The following is a description of a gene set: species: Homo sapiens Human Gene Set: KEGG_MEDICUS_VARIANT_MUTATION_ACTIVATED_GNAS_TO_CRHR_PKA_ACTH_SIGNALING_PATHWAY Mutation-activated GNAS to CRHR-PKA-ACTH signaling pathway. Pathway ID: N00326. Pathway type: Variant. Pathway class: nt06360 Cushing syndrome. Pathway Definition from KEGG: GNAS* -> ADCY -> cAMP -> PKA -> CREB -> ACTH, and this is the list of marker genes: ADCY5, CREB3L4, ADCY2, CREB3, CREB5, ADCY3, GNAS, PRKACG, ADCY6 (adenylate cyclase 6), POMC, PRKACA, ADCY9, ADCY4, ADCY8, ATF2, ADCY7, ATF4, PRKACB, ATF6B, CREB3L3, CREB3L1, ADCY1, CREB3L2, CREB1